Given this list of marker genes EDC3, PAN3, EIF4ENIF1, CNOT6, CNOT2 (NCBI Gene Id 51498), CNOT1, NOCT, TNRC6A, LSM3, PAN2 (poly(A) specific ribonuclease subunit PAN2), LIMD1, ATXN2, NBDY, RC3H1, PATL1, DDX6, LSM4, AGO2, LSM14A (NCBI Gene Id 91161), CNOT6L, PATL2, CNOT7, DYNC1H1, here is a description of the gene set: The aggregation, arrangement and bonding together of proteins and RNA molecules to form a cytoplasmic mRNA processing body. studied in species Homo sapiens Human Gene Set: GOBP_P_BODY_ASSEMBLY